Given this list of marker genes KCNJ1, CLCNKA, IKZF1, KCNJ10 (NCBI Gene Id 3766), BSND, CLCNKB, HLA-B, HSD11B2, SLC12A1, here is a description of the gene set: species: Homo sapiens Human Gene Set: HP_HYPOKALEMIC_METABOLIC_ALKALOSIS Hypokalemic metabolic alkalosis